Given this list of marker genes Awat2, Opn1sw (opsin 1 (cone pigments), short-wave-sensitive (color blindness, tritan)), Dhrs3 (NCBI Gene Id 20148), here is a description of the gene set: electronically inferred by orthology from the curated human pathway This event has been computationally inferred from an event that has been demonstrated in another species.<p>The inference is based on the homology mapping from PANTHER. Briefly, reactions for which all involved PhysicalEntities (in input, output and catalyst) have a mapped orthologue/paralogue (for complexes at least 75% of components must have a mapping) are inferred to the other species. part of: Visual phototransduction Reactome Pathway: The retinoid cycle in cones (daylight vision) studied in species Mus musculus